The following is a description of a gene set: Human Gene Set: GOBP_MITOCHONDRIAL_TRNA_PROCESSING The process in which a pre-tRNA molecule is converted to a mature tRNA, ready for addition of an aminoacyl group, in the mitochondrion. species: Homo sapiens, and this is the list of marker genes: TRMT61B, TRMT5, ELAC2, HSD17B10, GTPBP3 (GTP binding protein 3, mitochondrial), TRMT10C, PUS1, MTO1, TRNT1, PRORP, TRIT1, METTL8, RPUSD4, CDK5RAP1